The following is a description of a gene set: Human Gene Set: TRAVAGLINI_LUNG_PROXIMAL_CILIATED_CELL from publication Travaglini KJ, Nabhan AN, Penland L, Sinha R, Gillich A, Sit RV, Chang S, Conley SD, Mori Y, Seita J, Berry GJ, Shrager JB, Metzger RJ, Kuo CS, Neff N, Weissman IL, Quake SR, Krasnow MA (PMID 33208946) studied in species Homo sapiens, and this is the list of marker genes: ZBTB18, SAXO4, NUDT5, SUGP2, COPB2, IDS, ZNF609, RBKS, NGRN, EXOSC4, SMAD4, DRC3, ANKMY1, METTL27, MYCBPAP, TSNAXIP1, PPP1R7, CABCOCO1, CFAP91, GFOD2, FAM81B, CLXN, SMDT1, DGCR6L, GTF2A2, SYBU, CAPN2, BCAS1, RP1, ALG1L1P, NCF2, MYO1E, ELOB, DYNC2I2, MRPS28 (mitochondrial ribosomal protein S28), MAP1LC3A, GNS, UXT, CCDC81, AK7, FIBP, LAP3, CFAP58, PRR7, DZIP1, FOXJ1, LDHB, RAD9A, CDHR4, NDFIP2, SERTAD2, GOLPH3L, KAZN, DMAC1, ENSG00000286190, TMC5, TMEM121, MORN3, BLOC1S1, RABGAP1L, CFAP221, PAIP2, NAA38, ASL, IFT70B (NCBI Gene Id 150737), PKIG, GPX8, PPP1R14C, ERGIC3, ZFP90, STIP1, ZNF106, TNFRSF19, ANKRD37, MTCH2, FAM50B, ERBB4, KBTBD4, LRRIQ1, SMPD2, UBA1 (ubiquitin like modifier activating enzyme 1), KIF21A, TMEM67, COMMD6, AGBL5, C7orf50, HRAS, KLHL6, PSMD10, TRIM37 (NCBI Gene Id 4591), FRMPD2, STK11IP, TRIM41, PIGP, MARCHF10, PIN4, DNAH12, CD59, CFAP69, CATSPERD, C6orf132, ZNF428 (NCBI Gene Id 126299), MFSD6, NSFL1C, TNRC6B, PLXNB1, EAPP, SANBR, PITX1, VWA3B, CCDC146, IFT88, PDLIM4, PALMD, CIMAP1B, CFAP45, PGM2L1, WDR90, MRPL47, DNAJB6, DNAH2, NDUFB7, PXN, AGTRAP, SMARCA4, CIMAP3, AZIN1, SLC4A11, MPDZ, CC2D2A, APCDD1, DYNLT4, SFXN3, MUC4, NUCB2, CAMK1D, NICOL1, FAM174A, MAPK8IP1, SPATA6, UACA, WRAP53, ATP5F1E, SSBP1, IFT56, EFCAB12, CTBP2, PGLS, ZKSCAN1, ACTR2, SRPK2, KCNE3, SPAG16, CLIC6, KRT42P, ATP5MC2, C5AR1, AKR7A2, EMB, SSBP4, CGN, SF3B6, STAU1, NPTN, ATP5MG, MSH3, WDTC1, MPLKIP, TXLNB, CFAP298, USP10, DTHD1, LIMK2, MEIG1, ALKBH5, TMEM45B, CFAP77, FTO, ZNF664, IFT74, SPATA24, LSM3, KIFAP3, AK9, KPNA6, DERL3, DNAH7, FAM107B, CELSR1, SNRPE, EEF1AKMT1, DTX3, PCSK5, CEP97, MED25, PSMD9, ZMYND12, C22orf23, STRBP (NCBI Gene Id 55342), LINC01186, SYNE2, LMO2, TBC1D8, BICDL2, SLC27A2, PRMT5, CEP104, TOGARAM1, BAIAP2L1 (BAR/IMD domain containing adaptor protein 2 like 1), MARCKS, APPL2, ERCC3, RHPN1, POP5, NBEA, PKN1, TTC39C-AS1, RRAGA, COPS9, MAZ, SHROOM3, ATOX1, SERF2, COA3, TUBB4B, WFDC21P, WDR13, DRAM2, CHCHD2, DCDC1, CLOCK, LRRC74B, FANCF, CES1, GLYR1, RRP12, BBIP1, CCDC170, ANAPC15, PLAC8, FLACC1, TMEM160, PPIL6, COX7B, CATSPERE, NHERF1, CEP83 (centrosomal protein 83), IFT25, NDUFB1, CCT6B, ANKRD35, SAPCD1-AS1, CLDN3, GNA11, DOC2A, CCDC57, CCDC125, SMIM19, CFAP157, UQCRC1, SDHC, CFAP44, LGALS3, PCDH7 (NCBI Gene Id 90855), ERLIN2, MAP3K19, CENPS (NCBI Gene Id 378708), LENG8, IQCB1, MNAT1, STIMATE, SPEF2, RBM27, EFHB, CSTF3, C5orf15, SPATA6L, STPG1, SNCAIP, SNRPG, ORAI2 (NCBI Gene Id 84917), TBL1XR1, LCA5L, LASP1, TCP1, CIPC, PTGR1, HCG14, RAB11FIP4, HYDIN, DYRK1B, ICMT, UNC119B, TTC29, JHY (junctional cadherin complex regulator), F11R, FBXW9, CEP43, CUEDC1, ZBTB44, UQCR11 (NCBI Gene Id 10975), AK8, CARS1, S100A11, TMF1, SLC35A3, ADA2, C6orf226, BIK, PWWP2B, BROX, CCN2, TPPP, RBM38, ARL6IP4, EVI5, SYNE1, CNOT11, SRD5A2 (steroid 5 alpha-reductase 2), ABHD12B, CENPM, ADGRF1, DGCR6, FHAD1, PKIB, PINLYP, RBX1, CLSTN1, ICA1L, GPR107, FAIM, MED31, HINT2, NUP50-DT, BBS9, MGST2, CCDC17, CCP110, OTUD6B-AS1, PRRT3, CARHSP1 (calcium regulated heat stable protein 1), C11orf97, CCDC88C, ZNF440, OR7E47P, SEM1, SLC6A6, CCDC190, MRPL40, DDR1, AGPAT5, DAAM1, GK5, CD24, GABARAP, LRP8, CFAP251, CYP4B1, CAST, NUDCD2, PPID, FXR1, ELK3 (ETS transcription factor ELK3), DPM1, MAP3K2, HNRNPC, AKAP9, WRNIP1, DNAAF11, WDR19, RPS27L, LAMTOR2, EFCAB10 (NCBI Gene Id 100134776), FAM227A, ATP2C2, SRD5A3, BCO2, DALRD3 (DALR anticodon binding domain containing 3), DSTN, CLDN7, ENPP5, BANF1, SCGB2A1, SPMIP6, PSMB3, KIAA1671, SPACA9, WNK1, RSPH4A, RAC1, NAP1L4, JOSD2, UBE2T, TOMM34, C6orf118, VPS13C, LEPROTL1, UBXN11, NDUFB3, RFX3 (NCBI Gene Id 5991), DENND6B, IQCH, USP43, FBXL2, SPATS1, HSPD1, MDM1, CTNNA1, BECN1, IQCD, MORF4L2, LINC02265, ZC2HC1A, DNAH6, GIPC2 (NCBI Gene Id 54810), CHMP5, LSM5, MTIF3, NDUFC1, CRIP1, SLC25A4, EMC6, GABPB1-AS1, INTS10, DUSP18, VWA3A, TP53BP1, CFAP107, H1-2, GPR162, TPRG1L (tumor protein p63 regulated 1 like), CDC26, WDR35, NDUFB8, RSPH3, ECT2L, AGR2, PFDN5, TMT1A, ROPN1L, MISP3, ETFB, EFCAB11, PHIP, CFAP126, PPP2CB, H1-10, ARMH1, DNAH5, CFAP95, CIBAR2, UBE2L3, CROCCP2, LRRC23, SAMD15, CALM3, FBXO36, DNAAF10, H2AC8 (NCBI Gene Id 3012), SATB1, SELENOW, C7orf57, ENDOG, FOXP1, PSMB1, SEC14L3, CIMIP2B, SLAIN2 (NCBI Gene Id 80106), ST13, MDH1, STUB1, CENPBD2P, SHOC2, ZBBX, MRPL18, FANK1, CCHCR1, ANKRD13D (ankyrin repeat domain 13D), DZIP3, CDH26 (cadherin 26), ATXN2, SPATA18, TUBA1A, SOAT1, ATP5ME, HES2, EFHC1, C10orf67, H2BC21, DYNC2I1, MIPEP, REST, TMEM258, ECRG4, DCDC2B, SCRN1, PPP1R42, SLC7A2, UCP2, CFAP100, HIPK1-AS1 (HIPK1 antisense RNA 1), NDUFAF3, COX7C, MISP, PLPPR3, PIR, CFAP206, MRPL51, FGF14-AS2, CTXN1, TMEM14B, TTC16, IQUB, RASGEF1B, PCM1, ARHGAP4, WDR24, TBCA, CIBAR1, TMEM190, ODAD2, PLEKHA5, CIB1, RNPEP, GLIS3, TWF1 (NCBI Gene Id 82712), CLIC1, UBE3D, CPSF2, RPP38, PSMA4, B3GALT4, SYTL1, MYB, SLC44A4, CFAP141, ZCRB1, VSTM2L (V-set and transmembrane domain containing 2 like), EP400, GOLGA2P5, C20orf96, BUD31 (NCBI Gene Id 8896), LY6G5C, ENKD1, ACSS1, TAX1BP1, BPTF (bromodomain PHD finger transcription factor), GSTA1, LKAAEAR1, ATXN7L3B, LXN, KIF19 (NCBI Gene Id 203397), GADD45GIP1, CFAP20, SAP18, ANKRD54, MAPK15, GOLM2, ZFHX2, DSP, CEP126, SSBP3, C4orf33, PLPP5, C6, YWHAH, SPNS1, NBR1, BAIAP3, ANAPC5, IARS2, CCT5, GLIPR2, COL21A1, RIPOR2 (NCBI Gene Id 9750), HSP90B1 (NCBI Gene Id 7184), CALM1, IFT172 (intraflagellar transport 172), NHSL3, MTURN, GET1, C10orf95, MATCAP2, ABAT, TRAPPC2L, NDUFA2, TRIP12, STIM2, USP9X, ZSCAN18 (NCBI Gene Id 65982), SPATA33, CKB, CATIP, DCBLD2, TOGARAM2, ANXA11, PIN1, EMC2, CFAP119, VRK3 (VRK serine/threonine kinase 3), TMEM154, WFDC6, DRC7, RUNX1, ISCA1, CCDC74B, PDCD6, DNAI2, PPP6R1, ABCA5, ACYP1, ATP2A2, C2orf81, CBX5, C4orf3, DPY30 (NCBI Gene Id 84661), SMYD2, RAB36, LIMS1 (NCBI Gene Id 3987), KATNIP (katanin interacting protein), CLMN, ABHD11, SPATA7, LYSMD2, KDM1B, RPRD2, PYCARD, DYDC2, NDUFA13, CRACDL, COPB2-DT, UFC1 (ubiquitin-fold modifier conjugating enzyme 1), BOLA3, USP7 (NCBI Gene Id 7874), KIAA2012, CCDC66, UPF3A, EVL, LZTFL1, SPPL2B, MNS1, LRWD1 (NCBI Gene Id 222229), TEKT3, HEBP2, TFDP1, NDUFA7, BRD3OS, TYMP, PPP1R16A (protein phosphatase 1 regulatory subunit 16A), RIIAD1, CFAP144, LRTOMT, TEKT1, TRIM2, ATG9B, BAD, PLEKHB1, TENT4B, BCAS3, ISCA2, FAM13A, DCTN3, HSD11B1L, SMIM5, SLC25A36, UBL5, MORF4L1, TMEM232 (NCBI Gene Id 647447), NET1, TMEM107, P4HTM, CTSS, ZMAT2, CCDC89, BCCIP, MICOS13, ERH, GMPPB, CCDC34, CAPS (calcyphosine), ANKZF1, LARP6 (La ribonucleoprotein 6, translational regulator), GIHCG, DDB1, SLC38A4-AS1, GAS2L2, IRX3, SF3B2, GAR1, HINT1, PIERCE2, DMKN, PNKP, ST6GALNAC1, MAT2B, EIPR1, PZP, DNAAF1, ITGB4, NSMCE1, RSPH14, RPL36AL, MRLN, CFAP20DC, LRRC46, TSPAN6, RANBP9, KLHDC10, MMP24OS, ZNF273, DYNLT5, C2orf74, SEPTIN9, NAT1, PHTF1, EFHD2, CHCHD1, GTF3C1, MCAT, ISCU, TSPAN2, IFT46, MAP9, TAGLN3, MOK, FAM120A, GPX4, HECTD1, RBM43, NDUFA3, TUSC3, IP6K1, HSBP1, PYCR2, PRUNE2, KDM2A, LYRM2, CCDC148, MIRLET7BHG, IDH3A, MAGIX, DNAH11, MRPL22, GID8, KCTD12, DNPH1, UBR5, H2BC5, CBY1 (NCBI Gene Id 25776), GLE1, SOD1, PSMD4, HDLBP, NFU1, UQCC3, DGKH, PRDX5, GCLC, PERP, VILL, ARB2A, RALGAPA2, STOML3, LMNTD1, FHOD1, RABL2A, TTLL10, CLBA1, TECR, SKP1, KLHDC9, CCDC60, MRPS33, SRP14, SF3B5, TM9SF1, WDR49, FXYD1 (NCBI Gene Id 5348), MICOS10, PRR13 (NCBI Gene Id 54458), ABCC5, RPGRIP1L (NCBI Gene Id 23322), IRF9, CCDC65, C22orf15, ADSS2, APOD, MORN5, NME5, ATP5F1A, MAFG-AS1, TMEM218, CEP41 (centrosomal protein 41), SNW1, CST6, SNRNP25, CES4A, KCNH3, ALDH1L1, GPX1, CFAP299, STING1, SUN1, DNAAF5, EHBP1L1, WDR54, TRADD, CYB561, HMGN3, BBOF1, GNB2, ZDHHC1, RUVBL2, PLAAT2, HDGF, ODAD4, ROMO1, PHF11, KIF3A, IRF6, SRI (NCBI Gene Id 6717), PCNX4, CFAP54, OCEL1, CERKL, UBB, GAS8, IFT80, PACRG, GMPR2 (guanosine monophosphate reductase 2), MBTPS1, LRRC58, SLC25A24 (solute carrier family 25 member 24), SPCS1, AFDN, CEP162, C1orf87, UBAC1, APOO, UBXN10, KATNAL2, CUTA, GNG12, CLHC1, CETN2, ZNF652, LARP7, ABI2, GNAS, NEDD8, OTUD4, ATP5PF, SUGT1, TJP2, ACTR6, LIAT1, CYB5D1, CLTC, ZNHIT1 (zinc finger HIT-type containing 1), TFPT, DAZAP2, ARL3, MRPL43, CNIH2, GNA14, CCDC25, TRAK1, ADH6, CAPSL, MYO5B, TSPAN3 (tetraspanin 3), ODF2, CFAP70, TTLL5, NDUFA4, TSPAN1, REPIN1, TTC21B, STK40, NUP50, OGFOD2, ZC2HC1C, SMAP2, LAMTOR5, MRPL57, NR2F6, MPC2, CRISPLD1, GK, PSD3, HMGB2, PARK7, TCTN1, MRPS16, COA5, KCNRG, UMODL1-AS1, DHX30, CFAP300, SPA17, DTX2, MZF1, TSGA10, BDH1, DNAAF8, SPAG1, GON7, DYNLL1, NDUFB2, ERCC1, TTC32, RSPH9, HOATZ, KTN1, TXNRD1, PPP4R3B, CCNDBP1, CCNA1, AGPAT3, SYNGAP1, ARMC3, LRRC56, LAMTOR4, TMEM254, SLC25A29, C1orf141, BUD23, GBP6, BBS1, AHNAK2, C9orf72, RTP4 (NCBI Gene Id 64108), FYB2, DHRS9, MTMR6 (NCBI Gene Id 9107), AHSA2P, DLEC1, TACC2, DIAPH2, DHX32, COX6C, NHLRC4, ZBED5-AS1 (ZBED5 antisense RNA 1), KIAA2013, KIF9, SH3D19, CKLF (chemokine like factor), BCL2L1, COQ4, IFT70A, TMEM50B, TPGS2, DLGAP1-AS1, SIGIRR, FAM200B, ERICH2, DNAAF3, ALMS1, AKAP14, CCAR1, ACLY, NFIA, VWA5A, CDH1, FBXO15, FBXL13, DDX42, TRIR, XRRA1 (NCBI Gene Id 143570), DDX17 (DEAD-box helicase 17), PUM2, C11orf16, PPOX (protoporphyrinogen oxidase), PEX16, SUB1, CCT8, ZMYND10, IFT140, WDFY1, MIF, H2AJ, VRK1 (NCBI Gene Id 7443), SMIM14 (small integral membrane protein 14), PDCD6IP, WDR86-AS1, ERCC4, ATP5MK, COPS8, MRNIP, EMG1, NRAV, TMEM59, EEIG1, TRIP13, RAB11A, PSMB10, CCDC138, DNAJA4, B9D2, NCK2, TTC12, LRRC71, EIF4G2, TOMM6, LCOR, TP53INP2, CHURC1, VCAN, MAP1B, CNOT6, RHOU, GLT8D1, RABL6, PLEKHG7, ALOX15, CEP350, NEK11, NAT14, GSTA2, CEP89, RALB, FGGY, L3MBTL2, COX7A2, STAG3, SMPD3, CPLANE1, SMIM22, B3GNT5, KRT80, GAS7, CHMP2A, LRRC61, DEGS2, VCF2, ANKRD65, NAP1L1, CSPP1, CFAP65, RAD50, PLAAT4, CITED4, UPF1, CCDC33, SIX4 (SIX homeobox 4), CYSTM1, TTC39C (NCBI Gene Id 125488), BBLN, TLCD2, MTSS2, C21orf58, UBL3, SRGAP3-AS2, CCDC103, MGAT5, MRPL20, MUC12-AS1, PRSS12, RPGR, PFN2, SPEF1, NDUFC2, RFX2, TRAPPC5, HIBADH, PSENEN, TEX9, PSMD6, RRAD, SOX2, POLD2, PAPOLA, SYTL3, NDUFA1, PDIA4, SLC51B, CCL28, C6orf52, PLA2G10, TMEM131 (NCBI Gene Id 55369), CD164, SPATS2L, NIN, USP51, TP73, PROM1, NANS, RB1CC1, ARSD, DUOX1, TLE5, SLC25A14, EPPIN, NEK4, ZC3H6, FDXR, ENPP4, MYCT1, AGBL2, IFT57, REC8, CDS1, SEMA3C, SYTL2, DNAL1, ANXA1, CHCHD10, GIPR (NCBI Gene Id 2696), ATP5MF, ECI1, WDR45B, PEX11G, SURF2, FABP6, TTC9, PART1, ARL4A, KNDC1, GPATCH1, LRRC18, ODAD1, MLXIP, CFAP52, FAM210B, CES2, HSP90AA1, GCHFR, TMED10, C12orf75, OMA1, FIS1, SBNO1, KCNE1, AHSA1, TRMT1L, CFAP36, DYNLRB1, ZNF33A, CIAO1, CAP2, ERICH3, ANKRD26, CFAP410 (cilia and flagella associated protein 410), SMARCA2, DYNLT1, MT3, IFT122, SPG11, FOXO3, FAXDC2, NACC2, ANKRD66, DYNC2LI1, H2AZ2, DNAH3, MRPS18C (mitochondrial ribosomal protein S18C), PNMA1, NME7 (NME/NM23 family member 7), MB, GCC2, DAPP1, ENKUR, PTPRF, NUDC, SLC30A5, PSCA (NCBI Gene Id 90297), MRPL13, MAP6, ASB1, SNRPD1, MTF1, GABARAPL2, ESYT2, AZU1, LMLN, TTF1, CCT4, MBD2, LCA5, OAZ1, NAA20 (N-alpha-acetyltransferase 20, NatB catalytic subunit, NCBI Gene Id 51126), IGF1R, CCDC40, ARMC2, NDUFA8, LINC01436 (NCBI Gene Id 100996609), SLC35A2, TTC21A, BICDL3P, CSTPP1, SGSM3, WDR93, DNAJC10, PRKCE, TRPT1 (NCBI Gene Id 93089), MATR3, DRC12, SNHG10, CTBS, EIF4G3, CLUAP1, AGR3, MAPRE3, SPAG17, SPAG7, CTNNAL1, NARS1, CCDC78, IFTAP, POLR2I, PIERCE1, BBS2, GSTP1, BEST4, PTPMT1, UBE2H, CEP131, IQCE, CCDC39, CTSL, CIMIP6, MTX1, NT5C3A, EPB41L1, PRR15, DNAI4, TNFAIP8L1, XPNPEP3, NDUFS3, NOSIP, MDH1B, JPT1, TUFM, KIF5B, SORBS2, VEZF1 (vascular endothelial zinc finger 1), MBOAT1, CYBA, ANKDD1B, HIPK1 (NCBI Gene Id 23323), SARAF, EHF, NELFE, NOP10, C22orf39, ABL2, LRRC45 (NCBI Gene Id 201255), SRA1, KMT2E-AS1 (NCBI Gene Id 723809), THYN1, FAM98C, IGFBP5, PPP1R36, ABITRAM, CCDC181, CERS6, ENAH, CACNG6, PLEKHS1, CCT7, ANKUB1, TMEM123, SPATA17 (NCBI Gene Id 128153), PTPRT, STMND1, COMMD8, DYNC2H1 (NCBI Gene Id 79659), ELOC, FUZ, LYRM7, CCDC74A, PUDP, FSD1L, IRAG1-AS1 (NCBI Gene Id 100129827), SS18 (NCBI Gene Id 6760), CAPS2, TP53TG1, DHX57, SERPINB6 (serpin family B member 6), ZNF688, ATP9A, PTPN3, RNF6, FBRS, NSUN7, ESPN, NDUFA11, TRAF3IP1, CFAP263, LRRC49, CDC16, IFT43, SNORC, SSB, HMGN2, PTBP3, BBS4, NWD1, DNAJA1, MRPS31, CASP7, GNAL, CFAP46, TMEM68, PLCH1, TPGS1, COMMD3, FCF1, MLF1 (myeloid leukemia factor 1), TEX26, LRRC4, SQLE, DNAJC16, CNOT1, RABL2B, LRRC10B, TPR, DENND2B, C1GALT1C1, SLC22A23, ADPRS (NCBI Gene Id 54936), CFAP53, SLC22A4, BAIAP2, DNAAF6, RBM20, CRIP2, SDCCAG8, GRIN3B, GPBP1, SCAND1, GAPVD1, TPPP3, CELF1, LDLRAD1, HMGN5, LSM4, PITPNM1 (NCBI Gene Id 9600), PLPP2, CDHR3, MYG1, MS4A8, TMC4, AUTS2, GEMIN6, STOX1, ZNF524 (zinc finger protein 524), MGST3, BTBD3, COX5A, GSDMD, ZNF33B, SCCPDH, SELENOH, EIF5, ASXL2, SAP30, CCDC80, FAM47E, MRPL53, OCIAD2, USP2, MUC15, CALM2, INHBB, ATP6AP1, SMIM26, KCTD1 (potassium channel tetramerization domain containing 1, NCBI Gene Id 284252), MTSS1, RIBC2, NDUFS6, GFM2, KATNB1, ZNF264, ITGB8, TULP3, UGDH, RCAN3, STYXL1, WDR73, CLIP1, ULK4, AZI2, CFAP43, STK33, CNDP2, JKAMP, CCDC157, PNKD, IPO4, TRIM29, DPCD, DNALI1, DNAH10, CCDC191, IQCK, PLAAT3, CETN3, MGMT, LRRIQ3, DZIP1L, MRPL54, INTS11, RPA3, NDUFB10, TP53AIP1, EFHC2, HSPBP1, ATP5PO (NCBI Gene Id 539), CHD4, WASHC3, TUBA4B, SPATA4 (NCBI Gene Id 170560), ARHGAP39, TXN, CRNDE, MKKS, ZNF473CR, XRCC1, ABCA13, STOML2, IGFBP2, LINC01571, TSPYL4, ME3, DYNLRB2, CFAP74, DMWD, GMDS, POMP, VPS35, MKS1, LINC02875, SIX1, CAVIN3, ILF3-DT, TIMP4, CIR1, MRPS21, COX6B1, CD164L2 (NCBI Gene Id 388611), SPAG6, MROH1, ZNF3, SAMHD1 (SAM and HD domain containing deoxynucleoside triphosphate triphosphohydrolase 1), IDNK, FAM221A, CMTM4, MACC1, TMEM40, ALDH1A1, CROCC, SEPTIN7, RPL26L1, TOB2, METTL26, CFAP73, ODAD3, LARS1, DNAAF2, TRIT1, MORN2, GOLM1, UGCG, IQCG, CFAP96, USP16, HSPH1, FAM229B, ELF1, DUSP14, DIXDC1, TMEM212, TMEM219, IFT81, UQCRQ, FGF14 (NCBI Gene Id 317685, fibroblast growth factor 14), BASP1, CMIP, PRKAR1A, DNAI1, ADD3, HAGHL, BORCS7, NR2F2, MRPL41 (mitochondrial ribosomal protein L41), PSMB7, MUC12, CASZ1, KANSL1L, HSPA8, TSPAN19, SPAG8, MAK, CISD1 (NCBI Gene Id 55847), USP22, MTMR2, PARVA, TXNL4A, XPO1, FOCAD, LRIG1, MARCHF6, SIVA1, DAW1, ACKR4, SYAP1, NPHP1 (nephrocystin 1), FBXL5, SNTN, CASC2, PSMG3, ABHD2, PRDX3, DHRS4-AS1, ETNK1, METRN, DDX3X, GFER, IFT27, WARS1, XRN2, MDM2, SLTM, WFDC3, IFT22, PCYT2, SNAPC1, ANXA7, MEAF6, MORN1, VDAC3, CAPRIN1, NEK1, ADGB, COPRS, NEK10, SEC14L1, PKD1, DNAI3, MYEF2, WDR38 (NCBI Gene Id 401551), NDUFAB1, TTC5, COX17, DNAL4, EZR, NQO1, ALDH3B1, PRR29, GTF2H5, CALML4, PIH1D2, PEX6, OSBPL6, CIMIP1, PTPRN2, ODF2L, SPTLC2, POP4, ABI1, ATP6V1D, ELMOD2, ARL6, ST6GALNAC2, IFT52, DNAH9, THOC7, IK, ARHGAP32, SUDS3, PRRG4, IQCA1, ZCWPW1, TJP3, ANKRD42, TMBIM6, CEP290 (centrosomal protein 290), LYL1, POFUT2, LRRC37A4P, KIF3B, SLFN13, CFDP1, NARF, TBCB, HSP90AB1, DNAI7, CRY2, LINC03086 (NCBI Gene Id 649786), ARHGAP18, SAXO2, APOBEC4, PSMA5, RPL23AP7, RHPN2 (NCBI Gene Id 85415), VCP, SRGAP3, AMZ2, TRIM44, CCDC69, KRT23, DNAAF4, MYH14, NEAT1, CD4 (CD4 molecule), CAMSAP1 (calmodulin regulated spectrin associated protein 1), HS3ST6, LRP11, CASTOR3P (NCBI Gene Id 352954), PSIP1, IDH2 (isocitrate dehydrogenase (NADP(+)) 2), ERICH5, ORC4, ORMDL2, ZNF204P, CHST6, SETX, ERLEC1, BPHL, CNTD1, B9D1, IGFBP7, CFAP184, HNRNPF (heterogeneous nuclear ribonucleoprotein F), RBM24, KIAA0232, CHMP4A, NDUFB5, DPM3, FOXC1, CFAP47, CFAP276, CAB39, LINC00467, BAALC, PNPLA4, ATXN10, PLXNB2, TUBGCP2, TM9SF2, SF3A1, CFAP90, SSRP1, UCKL1-AS1, YWHAE, UNC5B-AS1, GCLM, OSCP1, RAMP1, GLB1L, CHCHD5, STK36, PTGES3, CCL15, VIM-AS1, ERICH6-AS1, RPL39L, TSTD1 (NCBI Gene Id 100134860), SNX29, AURKAIP1 (aurora kinase A interacting protein 1), TEKT2, KIF27, SCAMP4, ATOSA, ITGB8-AS1, KDM3B, FOXA1, C16orf46, DRC1, LRRC34, SMIM6, SMKR1, FAM216B, TUSC2, LEKR1, FZD6, LARP1, MUC20, DNER, CHCHD6, MRPL23, UNC93B1, MROH9, TEKT4, ALCAM, KPNA3, HACD3, CCDC28A, REXO2, IQANK1, CMPK1, PRPF6, SNX14, TEAD1, MUC16, AMPD3, TMEM231 (NCBI Gene Id 79583, transmembrane protein 231), IL5RA, TP53INP1, NDUFS8, JPT2 (Jupiter microtubule associated homolog 2), MYLK (myosin light chain kinase), HACD4, RUVBL1, CFAP161, METTL5, EPB41L4B (NCBI Gene Id 87974), CCDC88B, EFCAB2, PCAT19, CCDC24, ZNHIT2, NUDT2, PSMB5, VAMP8, TFF3, SSNA1, HHLA2, GALNS, FAM161A, RGS22, COX6A1, PSMB9, ST6GALNAC6, UBXN4, CHST9, SERPINI2, DHX40, NDUFB6 (NCBI Gene Id 4712), CFAP57, FNDC11, RALGAPB, CNTRL, PRDX1, HES6, DNAH1, TRPV4, ACAP1, ANKRD45, IFT20, CLTA, TEDC1, DYDC1, FXYD3, C8orf76, SLC6A9, HILPDA (hypoxia inducible lipid droplet associated), AKNA, CFAP210, POC5, CCNY, STMP1, RSPH1, IRF2, CLCN3, DYNLT2B, CMTM6, HSPE1, RIBC1, MAP1A, ATP5MJ, CARF, DIDO1, LRRC73, PDPK1, ATP5IF1, DNAJB13, CEP19, STX16